Given this list of marker genes ENPP7P6, CHMP4A, TRIM14, SNX20, ZNF600 (zinc finger protein 600), KIF27, ZBTB16, MATK, A2MP1, CD96, AKAP13-AS1, SFI1, ERMP1, KLRB1, ENSG00000227355, RDH14, PTPN22, ABCD2, PLAC8, ENSG00000259097, LINC02361, IL27RA, ADGRG5, ABCA12, CDC42EP3-AS1, TM7SF2, SYS1-DBNDD2, RHOH, NPM3, SKAP1, CD6, LRRC57, NANP, TTC9 (tetratricopeptide repeat domain 9), CD7, MCTP2, PYHIN1, ABCB1, CD69, USF1, RUNX3, ICAM3, KIF21B, C12orf75, SIDT1, CARD11, GZMA, TESPA1 (thymocyte expressed, positive selection associated 1), HS3ST3B1, BICDL1, RPL30P4, HRG-AS1, GRIK4, LEF1, IL2RG, TCF7, WDCP, SEPSECS, ITK, HSH2D, TC2N, MAPK13, RORC, KCNQ5, LINC01013, NKG7, SLFN12L, TBC1D10C, TNFRSF10A, RIPOR2, BIVM-ERCC5, IKZF2, ANKRD53, CD2 (CD2 molecule), TOGARAM2, YES1P1, RASGRP1, DOCK8-AS2, CARINH, LTB, ZFAND4, RMI2, SEPTIN1, SLA2, HDHD3, INTS5, CRTAM, CFAP53, PCED1B-AS1, TSPOAP1, IFNG-AS1, IL2RB (NCBI Gene Id 3602), LLGL2, CD8A, RN7SL118P, CDHR1, GATA3, IL7R, LINC01592, SORL1, FGR, PTPRCAP, ZNF641, GNLY, SLC25A20, NCR1, CD3E, GALNT12, THEMIS, TMIGD2, TXLNGY, VAMP1, BCL11B, CD247, SH2D1A, PROCA1, SAMD3, IKZF3, KLRG1, PARP15, SCML4, ARL4C, SYTL1, MYB, ACAP1, IL18R1, here is a description of the gene set: The gene expression program underlying the specification of human cell types is of fundamental interest. The study authors generated human cell atlases of gene expression and chromatin accessibility in fetal tissues. For gene expression, the study authors applied three-level combinatorial indexing to >110 samples representing 15 organs, ultimately profiling ~4 million single cells. The study authors leveraged the literature and other atlases to identify and annotate hundreds of cell types and subtypes, both within and across tissues. Our analyses focused on organ-specific specializations of broadly distributed cell types (such as blood, endothelial, and epithelial), sites of fetal erythropoiesis (which notably included the adrenal gland), and integration with mouse developmental atlases (such as conserved specification of blood cells). These data represent a rich resource for the exploration of in vivo human gene expression in diverse tissues and cell types. from publication Cao J, O'Day DR, Pliner HA, Kingsley PD, Deng M, Daza RM, Zager MA, Aldinger KA, Blecher-Gonen R, Zhang F, Spielmann M, Palis J, Doherty D, Steemers FJ, Glass IA, Trapnell C, Shendure J (PMID 33184181) Human Gene Set: DESCARTES_FETAL_MUSCLE_LYMPHOID_CELLS species: Homo sapiens Marker genes curated from the annotated cluster as represented in the Descartes Human Gene Expression During Development database.